The following is a description of a gene set: studied in species Homo sapiens A febrile seizure is any type of seizure (most often a generalized tonic-clonic seizure) occurring with fever (at least 38 degrees Celsius) but in the absence of central nervous system infection, severe metabolic disturbance or other alternative precipitant in children between the ages of 3 months and 6 years. Human Gene Set: HP_FEBRILE_SEIZURE_WITHIN_THE_AGE_RANGE_OF_3_MONTHS_TO_6_YEARS Febrile seizure (within the age range of 3 months to 6 years), and this is the list of marker genes: TSEN2, GAMT, NEUROD2, GNB1, DTYMK, RPL10, MT-TK, TSEN34, SATB2, ALDH4A1 (aldehyde dehydrogenase 4 family member A1), U2AF2, MVK, TRIT1, SLC25A12, ASXL2, FAR1, DPP9, ACADM, RSRC1, ABHD16A, KCTD7, BCKDK, SCN1B, AP2M1, NFIX, SIK1, CACNA1H, EMC10, AP4S1, NPRL2, SLC32A1, HMBS, RFX7, COG4 (NCBI Gene Id 25839), DNMT3A, SPTBN1, KCNQ2, KMT5B, KCNJ6, SCN8A, PRRT2, GRM7, LMNB1, KCNA2 (potassium voltage-gated channel subfamily A member 2), WDR26, ARX, SETD5, GRIN1, PEPD, PSMB9, MAF, CPLX1, NPRL3, EFHC1, PNKP, HS6ST2, CRELD1, ATP1A2, CAMK2A, CLCN2, THUMPD1, PDE2A, RFX5, PCDH19, GABRA1, GNAO1, SLC25A22, RNU12, HNRNPR, CASR, ATP6V1A, SCN2A, TRIM8, GABRA3, PIGA, GPT2, SLC12A5, CNKSR2, PTH1R, DMXL2, JRK, STX1B, FBXO28, EHMT1, KCNQ3, APP, CHD2, AGO1, WDR11, SEPSECS, ADORA2A, VPS11, PIGP, SCN1A (NCBI Gene Id 6323), AASS, GALC, SCN3A, CASK, TBCD, SPTAN1, SLC13A3, DEPDC5, DYRK1A, GLS, CHD8, GABRG2, TBC1D24, CEP85L, PIGH, AUH, SYNGAP1, HCN2, SETBP1, GRIA2, GABRB3, ADGRV1, SLC44A1, SCN9A, OTUD7A (NCBI Gene Id 161725), DPYD, TSEN54, TAF4, TSEN15, MBOAT7, GRIN2A, GABRD, CACNA1A, SLC2A1, CILK1, PIGQ, HERC2 (HECT and RLD domain containing E3 ubiquitin protein ligase 2), CPA6, POGZ, SLC35C1, NEXMIF, SDHB, CACNB4 (calcium voltage-gated channel auxiliary subunit beta 4), HCN1, SRPX2, FGF13, AMFR, WAC, CDKL5, ERLIN2, SLC6A1, PGAP2, MBD5, ATP6V0C, KCNA1